Given this list of marker genes PDPK1, CCK, KIF1A, MEMO1, PENK, TIA1, PROCR, NUCKS1, MRPL47, CCL25 (NCBI Gene Id 6370), INTS8 (NCBI Gene Id 55656), TIMELESS, STK11, PSME3, MRPL4, FNBP4, STAM, TTC28, PXN, ANP32B, UBA1, LARS1, UBE2O, SVIL, FLCN, EFHD2, CHTOP, RNF34, RNFT1, PIGS, ANKS1A, CSTF2, HCFC1, PJA2, METRNL, ETV1, PFN1, UNC119B, PIK3C2A, CATSPERZ, ZNHIT2 (NCBI Gene Id 741), CPB1, CEP112 (NCBI Gene Id 201134), ACTR2, ZNF280C, VOPP1, PSMA2 (NCBI Gene Id 5683), RAB37, ASCC1, NIT2, POLR3F, PPP1R21 (NCBI Gene Id 129285), DHX8, ARHGAP17, OAS2, PARL, RARS2, PLA2G12A, SYNE1 (spectrin repeat containing nuclear envelope protein 1), PRDX1, PPM1G, GNA13, TRMT1L, DNAJA2, ITGB1, MAP2K4, PTX3, FBXW11, PRELID3B, ANKH, USP20, SLC39A11, SPHK2, DDX47, NOP9, SLC30A9, PRKCH, CRX, ALDH7A1, DCUN1D5, ABI1, MAPK3, CRYBB1, BCL2L2, DDHD2, TMEM38B, SNX2, MRPL51, NUDT3, KCNK13, PLK2, CHMP4B, RUFY3, HAX1, ZDHHC12, PDLIM2, DHCR24 (NCBI Gene Id 9800), STARD5, FUNDC1, RS1, SRXN1, SAR1B, ADCYAP1, CDC42SE1, SLC25A46, SPN, HSPA2 (NCBI Gene Id 3306), ARMCX4, POLE4, HBE1 (NCBI Gene Id 3046), ANXA6, PRXL2A, MRPL57, DHX16, DNAJB9, FBLN7, CYBC1, LRRC58, PDCD6IP, MINDY1, MED15, RPS6KA2, TTC7B, PSMD3, RNF25, SF3B1, ANAPC7, KAT7, PPP2R3A, GORASP1, TFEC, BCKDHB, ACOT9, TSPAN4, CCDC6, HMX3, CIC, CAMK2D, NFATC2IP, CGREF1, UBP1, USP15, MOB4, ZC3H12C, MSN, PIK3AP1, UBXN8, BMP5, TXK, HMGN5, RAC1, ITPKA, C1orf52, IDNK, POC5, AGAP3, RABIF, MAP3K8 (mitogen-activated protein kinase kinase kinase 8), ATF6, ATF6B, COMMD5, PCYOX1 (NCBI Gene Id 63081, prenylcysteine oxidase 1), SP110, SPCS3, IL1RN, SLFN12L, VIPAS39, NCOR1, RPS6, NKG7, GK, HMGA1, PSAPL1, ZMIZ2, SNX14, TRIM39, ARMC7, HAPLN2, SMC6, CD81, IER2, C5orf15, AP1AR, POU2F2, CAMTA2, XPOT, PES1, MYCL, LRP1B, RAP1A, RABEPK, DENND6A, MRPL2 (mitochondrial ribosomal protein L2), BCDIN3D, VAV3, TMEM106A, TOLLIP, ATOSB, TIAM1, SH3BP5L, here is a description of the gene set: species: Homo sapiens Genes down-regulated in comparison of dendritic cells (DC) stimulated with poly(I:C) (TLR3 agonist) at 0.5 h versus DC cells stimulated with Gardiquimod (TLR7 agonist) at 0.5 h. mouse primary BMDCs were stimulated with tlr ligands and gene expression changes were profiled on Affymetrix arrays Human Gene Set: GSE17721_POLYIC_VS_GARDIQUIMOD_0.5H_BMDC_DN from publication Amit I, Garber M, Chevrier N, Leite AP, Donner Y, Eisenhaure T, Guttman M, Grenier JK, Li W, Zuk O, Schubert LA, Birditt B, Shay T, Goren A, Zhang X, Smith Z, Deering R, McDonald RC, Cabili M, Bernstein BE, Rinn JL, Meissner A, Root DE, Hacohen N, Regev A (PMID 19729616)